The following is a description of a gene set: Human Gene Set: GOBP_NEURAL_TUBE_FORMATION studied in species Homo sapiens The formation of a tube from the flat layer of ectodermal cells known as the neural plate. This will give rise to the central nervous system., and this is the list of marker genes: CASP3, NODAL, FZD3, TCTN1, CFL1, WNT5A, SFRP2, MED12 (NCBI Gene Id 9968), TSC1, LHX2, BMP4, PTK7, IFT52, SKI, SALL4, LIAS, SPINT2, NUP50, CLUAP1, ARHGAP35, COBL, RARG, IFT57, BRD2, GRHL3, DVL2, SPINT1, VASP, ADM, DLC1, PTCH1 (patched 1), GDF7, MTHFR, FUZ, RGMA, SEC24B, RARA, CC2D2A, CECR2, TRAF6, FOLR1, TSC2, LMO4, HIF1A, RALA, KAT2A, PRKACB, ST14, TMED2, PLXNB2, PRKACA, RPS7 (ribosomal protein S7), SFRP1 (secreted frizzled related protein 1), PAX2, SEMA4C, VANGL2, NOG, DEAF1, PFN1, LUZP1, KIF20B, SUFU, PRICKLE1, MKS1, SDC4, CTHRC1, TRIM71, SPECC1L, ALX1, STK4, SLC39A12, MIB1, LRP2, STK3, CDK20, TEAD2, GLMN, TGFB2, OPA1, CELSR1, ZEB2, TWIST1, IFT122, MTHFD1, TGFB1 (transforming growth factor beta 1), OVOL2, CITED2, GRHL2, APAF1, MTHFD1L, STIL, ABL1, TGIF1, SCRIB, FZD6, BMP5 (bone morphogenetic protein 5), TULP3, NCKAP1, PHACTR4, BCL10, BMP7, WDR83, IFT172, KDM2B, BBS4